Given this list of marker genes DNAJC7, DNAJB13, SELENOF, SH3GLB1, DNAJB4, DNAJC18, HSPA6, ST13, DNAJB12, HSPA1B, TOR1B, PTGES3, HSPA1L, HSPA8, ERO1A, HSPA14, ENTPD5, HSPA7, DNAJB14, DNAJB1, HSPA1A, HSPH1, TOR2A, UGGT1, HSPE1, HSPA13, HSPA2 (NCBI Gene Id 3306), BAG1, TOR1A, CD74, HSPA5, DNAJB5, HSPA9, here is a description of the gene set: species: Homo sapiens The process of assisting in the correct noncovalent folding of newly formed polypeptides or folding intermediates of polypeptides that have exited the ribosome and/or have been stabilized and transferred by other chaperone proteins. This process could involve several cycles of ATP hydrolysis. Human Gene Set: GOBP_DE_NOVO_POST_TRANSLATIONAL_PROTEIN_FOLDING